Given this list of marker genes NRP1, ADAMTS12, MET, BCAR1, MUC20, RAC1, ESM1, PTPN2, STMN1, PAK1, PTPN1, HGF, here is a description of the gene set: Human Gene Set: GOBP_HEPATOCYTE_GROWTH_FACTOR_RECEPTOR_SIGNALING_PATHWAY species: Homo sapiens The series of molecular signals initiated by a ligand binding to a hepatocyte growth factor receptor, and ending with the regulation of a downstream cellular process, e.g. transcription.